The following is a description of a gene set: Neighborhood of FOS v-fos FBJ murine osteosarcoma viral oncogene homolog in the GNF2 expression compendium Neighborhood of FOS Human Gene Set: GNF2_FOS studied in species Homo sapiens, and this is the list of marker genes: HK3, LGALS2, CD33 (NCBI Gene Id 945), NLRP3, PYCARD, VCAN, IER2, LILRA6, STX11, AP1S2, DUSP1, LILRA1, NOD2, CD302, CYBB, SCPEP1, FES, CAPG, CTSS, FOS, LILRB2, RNF130, TPP1, CFP, OTULINL, PLBD1, ZFP36, CPPED1, KLF4, MFSD1, NFKBIA, MS4A6A, DUSP6, ADA2, CD163, CD1D, FGL2, FCN1, CPVL, MAFB, NAIP